Given this list of marker genes Ptprf, Ppfia4, Il1rapl1, Ntrk3, Slitrk3, Ptprs (protein tyrosine phosphatase receptor type S), Ppfia1, Ppfia3, Slitrk6, Ptprd, Slitrk4, Slitrk5, Ppfibp1, Ppfia2, Il1rapl2, Ppfibp2, Slitrk2, Lrrc4b, Slitrk1, Il1rap, here is a description of the gene set: Mouse Gene Set: REACTOME_RECEPTOR_TYPE_TYROSINE_PROTEIN_PHOSPHATASES species: Mus musculus Receptor-type tyrosine-protein phosphatases